The following is a description of a gene set: studied in species Mus musculus Mouse Gene Set: GOBP_NEGATIVE_REGULATION_OF_HEMATOPOIETIC_PROGENITOR_CELL_DIFFERENTIATION Any process that stops, prevents or reduces the frequency, rate or extent of hematopoietic progenitor cell differentiation., and this is the list of marker genes: Zfp36, Pcid2, Hes5, N4bp2l2, Dpf2, Tcf15 (NCBI Gene Id 21407), Notch1, Nfe2l2, Mixl1, Hes1, Gata2, Myb, Hspa9, Tmsb4x, Mettl14